Given this list of marker genes NR0B2, PRAMEF6, RNF186-AS1, SKI, AURKAIP1, TBC1D3P6, LNCTAM34A, RPL12P14, LINC01128, C1QB, EXOSC10, PUSL1, SSU72, MTND2P28, TARDBP, EXOSC10-AS1, RNU7-29P (NCBI Gene Id 124904769), CICP27, MIR4684, UTS2, RPL21P21, CROCCP2, CTRC, HSPE1P24, CELA3B, TNFRSF14-AS1, ENSG00000287396, CNKSR1, FHAD1, NECAP2, DDX11L17, CAMTA1, RN7SL165P, RHD, MTND1P23, LINC01672, LINC01770, MIR4418, LYPLA2, TAS1R2, PEX14, ID3, TP73-AS2, SYTL1, PRAMEF7, PIK3CD-AS2, CRYBG2, ELOA, SNRPEP7, TP73, MIR6859-1, ENSG00000287356, PLA2G2F, TNFRSF18, PAQR7, RNU1-5P, MMP23A, ALDH4A1, PADI2, HNRNPCL4, CAMTA1-DT (CAMTA1 divergent transcript), HES5, CFAP74, LINC00339, CROCCP4 (NCBI Gene Id 102725047), ZBTB40, EXTL1 (NCBI Gene Id 2134), SLC25A33, SLC66A1, DDX11L1, FBXO2, C1QC, RN7SL451P, TNFRSF8, CLSTN1, CD52, PADI3, PRXL2B, MIR7846, CHCHD2P6, RERE-AS1, GPR3, RAP1GAP, MIR6859-2, CLCN6, PRAMEF32P, RN7SKP269 (NCBI Gene Id 106480915), MIR4253, RPL22P3, RNF186, DDI2, NIPAL3, EFHD2-AS1, PLA2G2D, SBF1P2, RNU6-1208P, MIR1290, GABRD, LINC02782, CCNL2, CFAP107, CELA2B, TAS1R1, CALML6, TNFRSF25, THAP3, DDX11L16, MFN2, PINK1-AS, RNU1-2, PNRC2, ALPL, SMIM1, ENSG00000310349, PLA2G2C, RPL23AP24, HTR1D, TMEM82, LIN28A, LINC01783, MIR6726, TNFRSF14, LDLRAP1, MIR3972, GALE, WBP1LP6, PPIAP34, PRAMEF13, AGRN, ENSG00000302217, ENSG00000221083, LINC01757, MICOS10-DT, ZBTB40-IT1, MYOM3, PADI1, TMCO4, BTBD6P1, EEF1A1P48, KIF17, MFAP2, NMNAT1, SDF4, C1orf159, PRAMEF25 (NCBI Gene Id 441873), C1orf174, GPN2, MST1P2 (macrophage stimulating 1 pseudogene 2), TENT5B, SRRM1, PDIK1L, MIB2, FAM131C, AADACL4, MIR6731, MIR3917, PDE4DIPP9, ICMT, KAZN, LINC02793, PEX10, MIR34AHG, NCMAP, RNU7-200P, PLEKHN1 (NCBI Gene Id 84069), RNU7-179P, CLIC4, RBP7, TMEM50A, ENSG00000298936, CDK11A (NCBI Gene Id 986), TMEM240, PRKCZ-AS1, TMEM52, RUNX3, ARHGEF19, PRAMEF8, SNRPFP2 (NCBI Gene Id 100874411), HES4, KLHDC7A, SYF2, H6PD, UBIAD1, NBPF3 (NBPF member 3), RNU5E-1, SAMD11, MIR200A (NCBI Gene Id 406983), MTCO1P12, CENPS, LINC03126, SLC45A1, GNB1-DT, PIGV, RN7SL277P, MORN1, AGTRAP, C1QA, ZDHHC18, CASZ1, ACOT7, KIF1B, AKR7L, CNR2, NUDC, MAD2L2, TEX46, RNU6-537P, ENSG00000237429, PDE4DIPP8 (NCBI Gene Id 124900582), RCAN3, MRPL20-DT, RNU6-1022P, RPL21P29, RN7SL614P, ANO7L1, SCARNA21B, NPPA, EFHD2, CAMK2N1, CDC42-AS1, MIR4632, PAX7, DFFA, CFL1P6, HMGN2P17 (NCBI Gene Id 100113373), HTR6, IFFO2, RNA5SP41, AKR7A2, GPR153, UQCRHL, GPR157, PFN1P10, FNDC10, MIR4695, SFN, RPL7P11, RN7SL304P, RNU6-1265P, PRAMEF9, RNU6-37P, RPS15AP6, RPS6KA1, LACTBL1, PDE4DIPP10, VWA1, LINC01342, CASP9, LINC01647, PRKCZ-DT (NCBI Gene Id 105378591), GRHL3-AS1, WASH9P, LUZP1, ENSG00000252404, FBXO44, VAMP3 (NCBI Gene Id 9341), RN7SL186P, RNU1-7P, MTOR, RNF207-AS1, CDC42, FHAD1-AS1, MIR6808, NOL9, CEP104, ENSG00000227066, HNRNPCL1, RN7SL679P, MEGF6, SRM, HSPE1P27, OSTCP2, MTFR1L, DISP3, RNU6-771P, LINC02596, ERRFI1-DT, FBLIM1, RPL32P6, SLC9A1, KDF1 (NCBI Gene Id 126695), RSC1A1, PRAMEF17, INTS11 (NCBI Gene Id 84139), LINC02766, WBP1LP7, IGSF21-AS1, EMC1-AS1, UBE2V2P3, CAMTA1-AS3, PRAMEF15, NBPF1, RUNX3-AS1, TTLL10-AS1, MIR6084, HSPB7, LINC02593, RPS4XP4, PLA2G5, LINC01345, PLCH2, PER3, ECE1, ENSG00000238316, ENSG00000301663, ACTG1P20, OR4G11P, AJAP1, PLEKHG5, UBE4B, RNU6-776P, LINC01346, CCDC27, CDK11B, LINC01355, LINC01646, PRDM16-DT, SCNN1D, SPEN, PRAMEF31P, CATSPER4, PRAMEF11, CORT, MMEL1, MUL1, PRKCZ, ATP13A2, CAMTA1-AS2, HMGCL, LRRC47, PRAMEF12, ENSG00000292994, LRRC38, TCEA3, MRTO4, PRAMEF10, RPL29P6 (ribosomal protein L29 pseudogene 6), ZNF683, TP73-AS3, MMP23B, VPS13D, LINC01777, ARID1A, CENPS-CORT, EIF4G3, CHCHD3P3 (coiled-coil-helix-coiled-coil-helix domain containing 3 pseudogene 3), EPHB2, OR4F29, MIR34A, RNU6-1199P (NCBI Gene Id 106480091), PITHD1, LINC01714, DDOST, SLC30A2, PADI4, RN7SL386P, ENO1, CDC42-IT1, EPHA8, ZNF593OS, ASAP3, TAS1R3, NCMAP-DT, LINC01786, TMEM201, H3P1, NPHP4, ZBTB2P1, SH2D5, TRNP1, FCN3, AKR7A3, DPPA2P2 (developmental pluripotency associated 2 pseudogene 2), HNRNPCL3, KLHL17, RNU6ATAC18P, TPRG1L (tumor protein p63 regulated 1 like), MICOS10, RN7SL731P, RNU6-291P, RER1, CLCNKB, NBPF2P, MAP3K6, DHDDS-AS1, RNU6-135P, RNU6-514P, WDTC1, FAM43B, SRARP, C1orf167, MIR3115 (microRNA 3115), PLEKHM2, RNU6-991P, PRAMEF14, ARHGEF16, WNT4, MIR4251, EMC1, PRAMEF28P, MT1XP1, RPL12P13, KCNAB2, IFNLR1, TTLL10, PARK7, SPATA21, RNU1-6P, AGMAT, RPL22, OR4F16, NADK, KLHL21, CHD5, ENSG00000278757 (U6 spliceosomal RNA), TTC34 (NCBI Gene Id 391205), CAPZB, ERRFI1, NPPB, GNB1, PHF13, PERM1, MMEL1-AS1, PRAMEF34P, PRAMEF1, PPP1R11P1, ICMT-DT, RCC2-AS1, MIR551A, MIR1302-2HG, HS6ST1P1, RNU6-1100P, RNU6-304P, E2F2, RPL7P7, PRDM16, MTATP8P1, SRSF10, PRAMEF2, B3GALT6, MIIP, NPM1P39 (NCBI Gene Id 440577), OTUD3, MTOR-AS1, ENO1-AS1, MTHFR, RPL7AP18, LINC02800, LINC01654 (NCBI Gene Id 101927876), UBE2J2, TBCAP2, CEP85, SPSB1, ENSG00000299881 (NCBI Gene Id 105376856, novel transcript), RNU6-48P, SPEN-AS1 (SPEN antisense RNA 1), RNU1-4, SLC2A7, CDA, MIR5697, MIR1302-2, PRAMEF27, GFOD3P, TNFRSF9, AADACL3, WASH7P (WASP family homolog 7, pseudogene), SLC35E2B, TRIM63, SLC35E2A, RNU1-3, MIR6729, NBL1, PLOD1, PANK4, WRAP73, HNRNPCL2, HES3, HMGN2, HNRNPR, TNFRSF1B, TMEM51-AS2, TNFRSF4, UBR4, LINC01635, EPHA2, SDHB, ATAD3A, RNU6-1072P, RNU1-8P, PRDM2, MTCO3P12, MIR3675, MST1L (macrophage stimulating 1 like (pseudogene)), PRAMEF20, FAAP20, CPTP, CROCCP3, UBXN11, PRAMEF26, PDPN, RNF207, ZBTB17, ESPN, PRAMEF5, ATAD3C, PRAMEF4, ZBTB48, DDX11L2, ENSG00000292993, LDLRAD2, ZNF593, LINC02783, CPLANE2, ENSG00000291156, SDHDP6, CELA3A, MIR1256, CTNNBIP1, FAM110D, MDS2, PRAMEF29P, LINC01409, DFFB, CROCCP5, FAM41C, RPL11, NDUFB4P8, ENSG00000253085, MTCYBP45, FBXO6, ZNF436-AS1, C1orf232, C1orf167-AS1, ANKRD65-AS1, PGD, BRWD1P1, LINC00115, FAM138A, KAZN-AS1, RNF223, USP48, ACAP3, DHDDS, CAMTA1-IT1, ESPNP, RNU1-1, PINK1, MXRA8, MFFP1, WDTC1-DT, TMEM222, MIR429, ATAD3B, RN7SL574P, GRHL3, CA6, ISG15, MACO1, PADI6, DNAJC16, SSU72-AS1, ARHGEF10L (NCBI Gene Id 55160), MASP2, CROCC, RNA5SP40, DVL1, CLCNKA (chloride voltage-gated channel Ka), OR4F5, SNORA70, MTCO2P12, ACTRT2, ANKRD65, C1orf127, MIR200B, MIR6730, ZNF436, LINC01141, GPATCH3, PRAMEF19, IL22RA1, IFITM3P7, LINC02781, CICP3, UBXN10, CICP7, MIR4689 (NCBI Gene Id 100616421), PLA2G2A, MRPL20-AS1, TUBB8P11, TMEM51, NOC2L, HP1BP3, RNU6-731P, PAFAH2, LINC02780, RNU4-28P, CD164L2, ACTL8, SLC25A34-AS1, PRAMEF35P, CAMTA1-AS1, C1QTNF12 (C1q and TNF related 12), RPL23AP19, CELA2A, EPHA2-AS1, STMN1, MICOS10-NBL1, MZT1P1, LINC02810, SNORA59A, FUCA1, ENSG00000259961, MRPL20, EIF1AXP1 (NCBI Gene Id 280661), SLC25A34, PGAM1P11, WASF2 (NCBI Gene Id 10163), LINC01772, ZPLD2P, ANGPTL7, MAN1C1, VWA5B1, IGSF21, RNU6-828P, SELENON, CD24P1, FBXO42, MIR1976, MIR6127, ECE1-AS1 (NCBI Gene Id 100509426), MIR378F, LINC01134, LINC02606, MYOM3-AS1, DHRS3, PRAMEF33, RPL23AP89, TMEM51-AS1, RNU6-777P, RNU6-110P, MIR6727, MIR6728, RPL17P9, FAM87B, PIK3CD, RN7SL649P, ELOA-AS1, RHCE, RPL39P6, KDM1A, DYNLL1P3, TMEM88B, DNAJC11, AUNIP, RPL36P5, KIAA2013, RPL10P17, PRAMEF36P, STPG1, LINC01784, RNU5E-4P, HSPG2, EEF1DP6, MIR4252, PLA2G2E, SZRD1, MPHOSPH6P1, TMEM274P, SLC2A5, ENSG00000284641, HES2, ENSG00000293331, PRAMEF18 (NCBI Gene Id 391003), RSRP1, ENSG00000238142, RCC2, FAM131C2P, SH3BGRL3, ENSG00000298156, RNU6-1099P, LZIC, RERE, DRAXIN, ENSG00000252691, MIR4425, OR4G4P, PIK3CD-AS1, MTATP6P1, RN7SL657P, PRAMEF30P (NCBI Gene Id 441870, PRAME family member 30, pseudogene), here is a description of the gene set: studied in species Homo sapiens Human Gene Set: chr1p36